The following is a description of a gene set: Human Gene Set: HP_MOTOR_SEIZURE Motor seizure A motor seizure is a type of seizure that is characterized at onset by involvement of the skeletal musculature. The motor event could consist of an increase (positive) or decrease (negative) in muscle contraction to produce a movement. species: Homo sapiens, and this is the list of marker genes: SETBP1, ABCC8, DNM1L, STXBP1, HIBCH, DPAGT1, FAR1 (fatty acyl-CoA reductase 1), DHX37, CLCN4, SLC38A3, VPS50, RALGAPA1, CHRNA4, MT-TL1, PNKP, CEP85L, PIGM, GRIA2, PAFAH1B1, MICOS13, KCNC2, MT-ND1, HDAC4, TSEN15, GRIK2, SLC25A22, NSD1, ATP5F1A, EN1, PRDM8 (PR/SET domain 8), INS, SLC1A3, KDM5C, CACNA1A, KIF5A, GRM7, SCN9A, RAB18, ALG2, ARFGEF1, NECAP1, NDUFA1, MACF1, SCN1B, KCNH5, MECP2, ADGRV1, ATP6AP2, EXOSC5, ALDH7A1, STAT3, BRAT1, TUBA8, CDC40, SUCLA2, RPS6KA3, ATP6V0C, UFSP2, SCN1A, KCNT2 (potassium sodium-activated channel subfamily T member 2), GABBR2, NSF, ACSF3, KIF5C, PPIL1, KCNB1, PCDH19, KDM4B, CILK1, KCTD7 (NCBI Gene Id 154881), CRH, EXTL3, KCNQ2, AFG2B, CHD2, ALG14, PIGT, HYMAI, LONP1, SLC35A2, TANGO2, SMC1A, TSEN2, CSNK2B, TUBB2B, NAXD, KARS1, SDHAF1, MT-ATP6, CDKL5, CUL3, NDUFAF3 (NCBI Gene Id 375340), NDUFAF8, SEPSECS, EXOC8, COX8A, CHRNA2, MED13, MFSD8, POLG (NCBI Gene Id 5428), PURA, AP3D1, GCDH, PRICKLE1, POLR1A, HNRNPU, MTHFR, TSEN34, OTUD7A, GNB2, KCNMA1, NDUFA2, GPHN, PLPBP, ALDH4A1, CACNA2D1, NDUFAF6, NEUROD2, NCDN, HCFC1, ATP7A, GNB1, DNM1, MRAP, LMNB2 (NCBI Gene Id 84823), PPP3CA, NTRK2, HID1, GRIN1, SV2A, ALG13, CLPB, TGFB1, ERCC5, PSAP, YWHAG (NCBI Gene Id 96443), ASAH1, GAMT, BUB1B, ASPA, DHFR, TRPM3, PI4K2A, MT-TS2, ATP6V1A, PEX3, EHMT1, SLC9A6, TUBB2A, NPRL2, DPM2, NEU1, MT-ND5, TMX2, PIK3CA, DHDDS, VPS53, SCN8A, RFX7, MMACHC, GCSH, AFG2A, ATP1A2, TRIT1, CABP4, PACS2, SRPX2, PRRT2, BTD, TBCD, CLCN3, SZT2, SLC35A3, DDX59, DPH5, COX4I1, PCDH12, FGF12 (fibroblast growth factor 12), ACTL6B, WDR45, SLC1A2 (solute carrier family 1 member 2), FBLN1, RUSC2, PPFIBP1, DNAJC5, MFF, ACBD6, CACNB4, CENPE, NPRL3, MT-TI, TUBB3, DALRD3 (DALR anticodon binding domain containing 3), SATB1, GABRD, BCKDK, CUX2, IER3IP1, MT-TF, RNU4ATAC, SLC32A1, NACC1, SLC1A4, MT-RNR1, CRELD1, ATPAF2, SQOR, HACE1, CACNA1C, ALDH5A1, MT-ND2, MGAT2, MBOAT7, RTN4IP1, CDK19, STRADA, SYNGAP1, CNPY3, DOHH, RNH1, COQ8A, TSC1, NBEA, PCYT2, SAMD12, GRN, UBA5, GOLGA2, CTCF, ATXN10 (NCBI Gene Id 9490), UBE3A, DENND5A, AFG3L2, SPTBN1, SMS, COX11, HCN1, ELOVL4, GALC, FZR1, SLC19A3, ZNHIT3, DHX16, GRIN2A, DCX, CLCN2, CDH2, KNSTRN, NAPB, GBA1, DPM1 (NCBI Gene Id 8813), GRIN2B, ATP5F1D, NEDD4L, NUS1, GABRA3, NGLY1, TPK1, NAGS, FBXL4, PIGL, DEPDC5, HK1, GM2A, COQ4, DMXL2, FBXO28, PTRH2, ADGRG1, MT-TV, RPL10, POGZ, KCNJ11, SLC6A19, SMARCAL1, EFHC1, GLYCTK, ARX (aristaless related homeobox), KCNK4, COL18A1, TRAPPC12, CAPRIN1, STX1B, ATP2B1, WDR45B, TMEM147, EIF4A2, ATP6V0A1, TBC1D24, UFC1, PIGA, LGI1, NTNG1, IREB2, CARS2, SCN3A, MT-TH, PIGW, SLC2A1, SYNJ1, OPHN1, GOSR2, MTHFS, GLUL, CSNK2A1, ATP5F1E, ASNS, NEUROG1, PHACTR1, MAPK10, TRIM8, NARS1, CHRNB2 (NCBI Gene Id 1141), SLC25A10, GABRG2, SLC4A10, KCNT1, GRIA3, RBL2, SNORD118, CLN8, GPAA1, HCN4 (hyperpolarization activated cyclic nucleotide gated potassium channel 4), NAXE, MDH2, NR4A2, MT-TK, APC2, EXOC7, KCNQ3, MT-TW, POMK, SCN2A, FGF13, JRK, MT-TP, STAMBP, TUBG1, DPYD, NHLRC1, PRUNE1, NDE1, AKT3, AARS1, ATP5MK, GABRA5, MT-ATP8, GABRA1, IFNG, MT-ND6 (NCBI Gene Id 4541), NDUFV1, PIK3CD, TUBA1A, GABRB3, CAMK2A, PRMT7, COG2, MED11, EEF1A2, FRRS1L, KCNA1, DOLK, KANSL1, CACNA1D, KCNQ5, GUF1, PLAGL1, GLB1 (galactosidase beta 1), SPTAN1, CELF2, ST3GAL3 (NCBI Gene Id 6487), ATAD1, IQSEC2, TSEN54, TBL1XR1, LAMC3, PLCB1, MT-TQ, SLC12A5, DOCK7, KCNA2, HEXB, PIGP, COQ5, PPP1R21, PYCR2, SETD1B, CIC, PTEN, CAMTA1, KIF11, MAST3 (microtubule associated serine/threonine kinase 3), CAMK2B, SDHD, D2HGDH, PIGQ, TRAPPC9, COG3, WWOX, POU4F1, MAPK1, GNAO1, MICAL1, ATP1A3, CASK, KCNC1, EPM2A, MT-ND4, CHD3, TIMM50, PDHA1, PGAP2, CTSD, AP2M1, RELN, CPLX1, PSAT1, SDHB, TSC2, PI4KA, SLC25A12, GCK, ADNP, ERMARD, HCN2, PIGH, NEXMIF, ARHGEF9, CNTNAP2, CTNNA2, LNPK (lunapark, ER junction formation factor), DYRK1A, ROGDI, SLC6A1, MT-ND3, GNAQ, CACNA1B, RNF13, PHGDH, UGDH, MTOR, FARS2, ADAM22, PDX1 (pancreatic and duodenal homeobox 1), ZNF526 (NCBI Gene Id 116115), PTPN23, GAD1, PGAP3, SLC25A15, SDHA, SMARCA2, SIK1